The following is a description of a gene set: CDH11 gene encodes Cadherin-11, also known as osteoblast cadherin (OB-cadherin). The CDH11 gene maps to chromosome 16, chromosomal band 16q22, which is a subject to recurrent genomic loss in some types of cancer. The CDH11 gene consists of 14 exons, which are known to encode two splicing isoforms. Both splicing isoforms are expressed in the heart, brain, placenta, lung and bone, but not in the kidney, skeletal muscle, pancreas and liver. Several transcription factors have been shown to directly regulate CDH11 gene transcription, including HOXC8, ILF3, ZEB2, HEYL, FOXF1, and BHLHE22, and the transcription of CDH11 has also been shown to be influenced by a number of growth factors and hormones, such as FGF2, TNF, TGFB1, TGFB2, GNRH1, PTH, dexamethasone, and progesterone. CDH11 can also affect TGFB1 signaling, thereby possibly creating a feedback loop. Expression of mouse Cdh11 in mouse osteoblast-like cell line (MC3T3-E1) is not affected by osteogenic hormones triiodothyronine (T3) and 1,25-dihydroxyvitamin D3 at either mRNA or protein levels. CDH11 mRNA has been identified as the target of several microRNAs, such as miR-200c-3p and miR-451a.<br><br>Like other classical cadherins, CDH11 associates with several catenin proteins through its intracellular domain, which is thought to play a role in the establishment and regulation of adherens junctions: CTNND1 (also known as p120 catenin or delta-catenin), CTNNB1 (beta-catenin), JUP (Junction Plakoglobin, also known as gamma-catenin), and CTNNA1 (alpha-catenin).<br><br>CDH11, through its C-terminus, also forms a complex with angiomotin (AMOT) isoform p80 (AMOT-2), which is implicated in CDH11-mediated cell migration and tumor cell invasiveness.<br><br>Through its extracellular region, CDH11 binds to the C-terminal fragment of ANGPTL4 (Angiopoietin-like-4), commonly known as cANGPTL4, which is implicated in the regulation of wound healing. The variant isoform of CDH11 (CDH11v), an 85 kDa membrane-bound fragment produced as a consequence of alternative splicing, can compete with the canonical CDH11 for cANGPTL4 binding, leading to diminished CTNNB1 release.<br><br>During normal development, CDH11 is implicated as a regulator of stem cell fate decisions, especially in mesodermal cell lineages, being particularly important for skeleton formation.<br><br>Besides cancer, CDH11 has been implicated in several other diseases, such as rheumatoid arthritis, fibrosis, cardiovascular diseases, and neuropsychiatric disorders. part of: Regulation of Expression and Function of Type II Classical Cadherins Reactome Pathway: Regulation of CDH11 Expression and Function studied in species Homo sapiens, and this is the list of marker genes: ANGPTL4, CDH11 (NCBI Gene Id 1009), CTNNA1, SP1, CDH8, AGO2, HEYL, TNRC6A, ADAM19, CDH24, SNAI1, ADAM33, AMOT, AGO1, BHLHE22, CTNND1, PRDM8, ILF3, FOXF1, AGO3, TNRC6B, MIR451A, MIR200C, AGO4, MOV10, CTNNB1, ZEB2, TNRC6C, JUP, HOXC8